The following is a description of a gene set: studied in species Homo sapiens Genes involved in pigmentation and melanocyte structure and organization were among the first identified targets of MITF. Expression of enzymes TYR, DCT and TYRP1, which work sequentially to eventually convert tyrosine into eumelanin and pheomelanin, is regulated in part by the binding of MITF to M-boxes in the promoters. MITF additionally regulates the expression of structural components of the melanosome such as MLANA, SLC24A5, SILV and GPR143, although direct binding and regulation has not been demonstrated in all cases. Genes encoding RAB27A and MYO5A, which regulate the localization and trafficking of melanosomes, are also targets of MITF. Reactome Pathway: Regulation of MITF-M-dependent genes involved in pigmentation part of: MITF-M-dependent gene expression, and this is the list of marker genes: ARID1A, RAB27A, SMARCC2, MYRIP, ACTB, ACTL6A, SMARCD3, SMARCA4, MLPH (melanophilin), SMARCD1, SS18, CREB1, TYRP1, DPF3, DPF1, MAPK14, BCL7B, MITF, DPF2, DCT, USF1, SOX10, ARID1B, TFAP2A, SMARCB1, BCL7A, SMARCA2, SS18L1, GPR143, PMEL, SMARCC1 (SWI/SNF related, matrix associated, actin dependent regulator of chromatin subfamily c member 1), MLANA, CTNNB1, AKT2, BCL7C, MYO5A, SMARCD2, TYR, IRF4, SYTL2, SMARCE1, LEF1